The following is a description of a gene set: BACKGROUND: Ovarian cancer (OvCa) most often derives from ovarian surface epithelial (OSE) cells. Several lines of evidence strongly suggest that increased exposure to progesterone (P4) protects women against developing OvCa. However, the underlying mechanisms of this protection are incompletely understood. METHODS: To determine downstream gene targets of P4, we established short term in vitro cultures of non-neoplastic OSE cells from six subjects, exposed the cells to P4 (10-6 M) for five days and performed transcriptional profiling with oligonucleotide microarrays containing over 22,000 transcripts. RESULTS: We identified concordant but modest gene expression changes in cholesterol/lipid homeostasis genes in three of six samples (responders), whereas the other three samples (non-responders) showed no expressional response to P4. The most up-regulated gene was TMEM97 which encodes a transmembrane protein of unknown function (MAC30). Analyses of outlier transcripts, whose expression levels changed most significantly upon P4 exposure, uncovered coordinate up-regulation of 14 cholesterol biosynthesis enzymes, insulin-induced gene 1, low density lipoprotein receptor, ABCG1, endothelial lipase, stearoyl- CoA and fatty acid desaturases, long-chain fatty-acyl elongase, and down-regulation of steroidogenic acute regulatory protein and ABCC6. Highly correlated tissue-specific expression patterns of TMEM97 and the cholesterol biosynthesis genes were confirmed by analysis of the GNF Atlas 2 universal gene expression database. Real-time quantitative RT-PCR analyses revealed 2.4-fold suppression of the TMEM97 gene expression in short-term cultures of OvCa relative to the normal OSE cells. CONCLUSION: These findings suggest that a co-regulated transcript network of cholesterol/lipid homeostasis genes and TMEM97 are downstream targets of P4 in normal OSE cells and that TMEM97 plays a role in cholesterol and lipid metabolism. The P4-induced alterations in cholesterol and lipid metabolism in OSE cells might play a role in conferring protection against OvCa. Human Gene Set: WILCOX_RESPONSE_TO_PROGESTERONE_UP from publication Wilcox CB, Feddes GO, Willett-Brozick JE, Hsu LC, DeLoia JA, Baysal BE (PMID 18070364) studied in species Homo sapiens Genes up-regulated in primary cultures of ovarian surface epithlium cells exposed to progesterone for 5 days., and this is the list of marker genes: EBP, SUMO1, NSDHL, IDI2-AS1, MON2, PRC1, SMC2, NUSAP1, CENPF, RGS2, PDS5A, HAND2, ADGRG6, FDPSP5, CDKN2C, CEP57, DNAAF2, THBD, KANSL1L, CEP55, TMEM97, FADS2, IFT74, ZBED2, ATG2B, KIF4A, WDHD1, CENPU, SC5D, DHCR7, DLGAP5, NEUROD1, RIF1, LIPG, LSS, ETV1, PLA2G4A, HBP1, ELOVL6 (ELOVL fatty acid elongase 6), GALK2, ITGBL1, IDH1, CNTN6, LGALS8, NUP160, PEG10, ACKR4, ZNF518A, HSD17B11, SEC14L1, HMGN3, HBD, MAP3K8, NPY1R, LPIN1, ACAT2, TK1, C7orf25, NCAPG, DNAJB9, TDO2, PCSK6, SGK3, TTF2, BBS10, ABCG1 (NCBI Gene Id 9619), DLX4, SAMD9, SMPDL3B, GOLGA8G, LYSET, FAXDC2, PBK, CXCL5, BBS7, CYP51A1, TMT1A, PRDM12, HMGCS1, SHCBP1, ADAMTS20, GK, FANCI, FADS1, TRPC4, IDI1, MDM1, DEPP1, CENPQ, ARHGEF3 (NCBI Gene Id 50650), CENPN, TLL2, KLF5, HJURP, CDC20, CRYGS, SGK1, IFNAR2, AREG, EVI2A, PPL, PTHLH, ZCCHC10 (NCBI Gene Id 54819), HMGB2, ASPM, CDK1, ZNF268, CYB5B, MVK, HBS1L, TOP2A (NCBI Gene Id 7153), CDKN2AIP, KCNJ16, LARP4, HBB, TNFAIP6, NPY, MUC5B, MAP7, SYNPO2L, XRCC4, INSIG1, NDC80, MTF2 (metal response element binding transcription factor 2), NKG7, MATCAP2, IFT70A (intraflagellar transport 70A), CCNB2, LDLR, KIF20A, SHMT1, HMOX1, FDFT1, MT1M, RNU6-73P, KLF6, CEP162, MSMO1, OTULINL, SCD, PCLAF, YTHDC2, CEP76, HMMR, HMGCR, RRM2 (NCBI Gene Id 6241), TYMS, KLHL24, FDPS, CCNB1, SMPDL3A, ORC4, CDC6